The following is a description of a gene set: Orexin and neuropeptides FF and QRFP bind to their respective receptors Human Gene Set: REACTOME_OREXIN_AND_NEUROPEPTIDES_FF_AND_QRFP_BIND_TO_THEIR_RESPECTIVE_RECEPTORS species: Homo sapiens, and this is the list of marker genes: NPFFR1 (NCBI Gene Id 64106), NPFFR2, NPFF, HCRT, QRFPR, HCRTR1, HCRTR2, QRFP